Given this list of marker genes Zdhhc13, Cbll1, Qser1, Raph1, Kcna2, Srgap1 (SLIT-ROBO Rho GTPase activating protein 1), Sp3, Katnbl1, Farp2, Sap18, Abcc2 (ATP-binding cassette, sub-family member 2), Ssr1, Fzd6, Rab11a (NCBI Gene Id 53869), Saxo2, Nipa1, Dimt1, Thsd7a, Spata6l, Cadps2, Gja6, Gpm6b, Itgb4, Cald1, Cntn1, Zbtb41 (NCBI Gene Id 98307), Ssxb10, Wapl, Znrf3, Lonrf1, Nampt, Pcdh7, Trio, Neurl4, Pax9, Zfp521, Dera, Camk4, Fam120c, Washc4, Kcnj6, Mstn, Tent4b, Ms4a5, Tpd52, Ube4a, Arhgap29, Vps29, Atp1b1, Skida1, Mylk, Cnot6l, Gpr45, Mageb16, Tubgcp4, Dnajc3, Arid4b, Hyal4, Caprin2, Dmxl1, Myb, Etfrf1, Gnai1, Crem, Cwc22, Terb2, Nek7, Fancc, Kdm1b, Cltb, Tmc7, Snx5, Eif4h, Myrf, Plppr5, Utrn (NCBI Gene Id 22288), Mtpn, Trappc8, here is a description of the gene set: species: Mus musculus from publication Chen Y, Wang X (PMID 31504780) Genes predicted to be targets of miRBase v22 microRNA mmu_miR_467e_5p in miRDB v6.0 with MirTarget v4 prediction scores > 80 (high confidence targets). Mouse Gene Set: MIR_467E_5P